The following is a description of a gene set: Any process that results in a change in state or activity of a cell or an organism (in terms of movement, secretion, enzyme production, gene expression, etc.) as a result of a starvation stimulus, deprivation of nourishment. species: Mus musculus Mouse Gene Set: GOBP_RESPONSE_TO_STARVATION, and this is the list of marker genes: Cdkn1a, Lrp11, Fads1, Pck1, Eif2ak2, Stk26, Tnfrsf11a, Asns, Plin3, Pak4, Bcas3, Micu1, Srebf2, Gabarapl1, Pak5, Foxk2, Plin2, Fnip1, Ifi203-ps, Gas6, Xpr1, Acat1, Hfe, Acadm, Krt20, Pik3c3, Nuak2, Zc3h12a (zinc finger CCCH type containing 12A), Vps41, Nupr2, Ywhaz, Ppara, Trp53, Bmpr2 (NCBI Gene Id 98751), Prkd1, Hrk, Prkag3, Mtmr3 (NCBI Gene Id 74302), Foxa3, Wrn, Rragc, Lrrk2, Lars1, Prkch, Tsc2, 4933438K21Rik, Ulk2, Tsc1, Gas2l1, Seh1l, Tcf7l2, Tbc1d5, Gabarapl2, Ifi209, Impact, Adm, Glul, Eif2a, Eif2ak3, Galp, Rragb, Stk-ps2, Alb, Rptor, Slc39a5, Cpeb4, Rraga, Ctsk, Dele1, Sesn2, Ralb, Eif2ak1, Nfe2l2, Usp33, Pak1, Pak3, Cps1, Flcn, Rnase4, Wnt9b, Inhbb, Srebf1, Ucp2, Gck, Atxn3, Pick1, Adcyap1, Kptn, Pcsk9, Stk24, Wdr45b, Hmox2, Pak6, Xbp1, Mtor, Gm14151, Ambra1, Dsc2, Hspa5 (NCBI Gene Id 99198), Jmy (NCBI Gene Id 57748), Ywhag, Pex2, Slc34a1, Pak2, Mapk8, Fbxo22, Ifi207, Tnrc6a, Dnajc15, Cad, Gpr155, Gip (gastric inhibitory polypeptide), Prkag2, Atf4, Pik3r4, Cadps2, Eif2s1, Foxk1, Mfsd2a, Yme1l1, Ifi206, Higd1a (NCBI Gene Id 80431), Zfp36, Rragd, Atf2, Hmgcs2, Gnpat, Sfrp1, Tfeb, Atf3, 4921509C19Rik, Mapk3, Nprl3, Eif2b1, Max, Smdt1, Slc7a5, Atg7, Map1lc3b, Sstr3, Sstr1, Ttc5, Wnt2b, Sesn3, Sirt1, Slc38a3, Fas, Ulk1, Upp1, Ucn, Ppm1d, Becn1, Mapk1, Clec16a, Nprl2 (NPR2 like, GATOR1 complex subunit), Mfsd5, Slc39a4, Myh13, Slc38a2, Wipi2, Gcn1, Wipi1, Cckar, Mios, Depdc5, Ddit3, Fos, Pck2, Foxo1, Zfyve1 (NCBI Gene Id 217695), Castor1, Angptl4, Yars1, Bmf, Pmaip1, Lamp2, Ifi213, Sar1a, Gba1, Ifi203, Prkag1, Trim32, Atg4b, Prkaa1, Pfkfb1, Ripor1, Szt2, Sstr2, Sesn1, Map3k5, Eif4ebp1, Ulk3, Ucn3, Map1lc3a, Pdk4, Slco2b1, Dap, Atg14, Pik3c2b, Fcor, Sar1b, Gpt, Rrp8, Prkaa2, Hspa8, Kat5, Comt, Tbl2, Ctsl, Ifi208, Foxo3, Mup1, Wdr45, Rnf167, Myod1, Mfsd11, Atg5, Hcrt, Gcgr, Ehmt2, Wnt4, Sh3glb1 (SH3-domain GRB2-like B1 (endophilin)), Wdr24, Klf10, Bcl2, Becn2, Chka, Jun, Ifi214 (interferon activated gene 214), Larp1 (NCBI Gene Id 73158), Itfg2, Adsl, Slc2a1, Mybbp1a, Elapor1, Cbl, Wdr59 (WD repeat domain 59), Tbc1d7 (NCBI Gene Id 67046), Bhlha15, Kics2, Mndal, Cartpt, Mcu, Sp7, Bmt2, Gabarap, Suv39h1, Pik3c2a, Eif2ak4 (eukaryotic translation initiation factor 2 alpha kinase 4), Ugt1a1, Rnf152